The following is a description of a gene set: A protein complex with palmitoyltransferase activity. species: Homo sapiens Human Gene Set: GOCC_PALMITOYLTRANSFERASE_COMPLEX, and this is the list of marker genes: SPTLC3, ORMDL3, GOLGA7B, ZDHHC9, SPTSSA (NCBI Gene Id 171546), SPTLC1, ORMDL2, ORMDL1, SPTSSB, GOLGA7, SPTLC2